The following is a description of a gene set: Human Gene Set: GOCC_DENDRITIC_SHAFT studied in species Homo sapiens Cylindric portion of the dendrite, directly stemming from the perikaryon, and carrying the dendritic spines., and this is the list of marker genes: SEZ6, GRM7, APP, EPHA4, GRM5, GPER1, HCN1, GABBR1, MPP2, MAP2, SYNDIG1, KIRREL3, CNIH3, MAP1A, HCN2, RGS7BP, JPH4, HTR2A, LPAR1, FLNA, BAIAP2, CRIPT, STAU2, SYNGAP1, PSEN1, ABI3, CNIH2, PRKAR2B, ZMYND8, PREX1, ZNF804A, KIRREL1, SLC1A1, NLGN2, RTN4R, FUBP3, INPP5J, NSF, GIPC1, NTSR1, GRIA1